The following is a description of a gene set: Mouse Gene Set: GOMF_TRNA_SPECIFIC_ADENOSINE_DEAMINASE_ACTIVITY Catalysis of the reaction: adenosine + H2O = inosine + NH3, in a tRNA molecule. studied in species Mus musculus, and this is the list of marker genes: Adar, Adat2, Adad1, Adarb2, Adad2, Adat3, Adat1, Adarb1